Given this list of marker genes Rad51, Brca1, Rpa1, Mlh3, Tesmin, Rec8, Spag8, Blm, Prm1, Prmt5, Stpg4, Rgs22, Spata33, Lhx8 (NCBI Gene Id 16875), Kpna7, Tsga8, H1f9, Patz1, Tsn, Terf2, Pcna, Csnk2a2ip, Oosp2, Slc2a1, Actrt3 (NCBI Gene Id 76652), Zmynd15, Kif6 (kinesin family member 6), Aire, Scml1, Rbmy, Cdk7, Kdm3a, Ran, Hmga2, Dnmt1, Rfpl4, H2ac1, Aurka, Taf7, Smarcb1, Topbp1, Scmh1, Mael, Tbpl2, Smarcc1 (SWI/SNF related, matrix associated, actin dependent regulator of chromatin, subfamily c, member 1), Sycp2l, Zbtb16, Kpna4, Taf10, Cdk2, Tbp, Chtf18, Adad1, Zfpm2, Trp53, Terf2ip, Trip13, Gtf2b, Sycp1, Tnp2, Top1, Tsx, Morc1, Trim24, Taf7l, Limk1, Stag3, Mlh1, Gtf2a1l, Aym1, Ankrd17, Stra8, Smarca4, Smad1, Hmga1, Actl7a, Zfp59, Pou5f1, Ctcf (CCCTC-binding factor), H2bc1, Ncapd3, Hmgn1, Taf4, Prm2 (protamine 2), Yap1, H1f7, Coil, Celf1, Dmrt1, Sycp3, Tbpl1, Ccnh, Hspa2, Dazap1 (DAZ associated protein 1), Haspin, Atr, Tcfl5, H1f8, Ankrd37 (ankyrin repeat domain 37), Rad18, Taf3, Marcks, Fbxo43, Tnp1, Hmgn2, H2ax, Top2a, Sohlh1, Spata24, here is a description of the gene set: species: Mus musculus The nucleus of a germ cell, a reproductive cell in multicellular organisms. Mouse Gene Set: GOCC_GERM_CELL_NUCLEUS